Given this list of marker genes GUCY1A1, ACTG2, GMPPA, RAD21, CLMP, FLVCR1 (FLVCR choline and heme transporter 1), COL4A5, AAAS, MYO1H, MRAP, SAMD9, ACTB, MYLK, STAT3, GLA, MYH11, ACTA2, TRAPPC11, IARS2, COL4A6, LMOD1, MYL9, MEIS2, IVNS1ABP, PHOX2B, here is a description of the gene set: Human Gene Set: HP_ABNORMAL_PERISTALSIS studied in species Homo sapiens Abnormal peristalsis An anomaly of the wave-like muscle contractions of the digestive tract.